Given this list of marker genes ARHGAP27, CDH10, NT5DC1, TEN1, ECRG4, AMD1, PYCARD, NEFH, DNALI1, PIGT, GLI3, TIGD2, MOXD1, SFT2D3, POMT1, KIAA1191, TOP6BL, SMTN, TMEM150C, ME3, SRRD (SRR1 domain containing), PGM5, COL8A2, PARM1, NEXN, ARHGEF10, RAB34, SERPINB5, RAMP2, PAK1, ROBO2, KAT5, FGL2, LINC00339, B3GALNT2, PWWP2B, FOS, RLN1, SORBS1, LSAMP, ISL1, EPHA3, CNOT6L (NCBI Gene Id 91275, CCR4-NOT transcription complex subunit 6 like), DBNDD2, NR2C2AP, SORBS2, FBXO22, ASB2, GABBR1, PDPR (pyruvate dehydrogenase phosphatase regulatory subunit), PPP3CB, CAPS (calcyphosine), BOC, HSPB8, ASAP3, HSD17B14, KLF4, B3GALNT1, PKP1, GTDC1 (NCBI Gene Id 79712), RBM24, KCNN4, SLC15A2, MVK, MVB12B, PSD2, LHPP, MIR100HG (mir-100-let-7a-2-mir-125b-1 cluster host gene), IER2, CACNA2D1, KRT15, RILPL2, PPM1L, VMP1, KLK10, TMSB15A (thymosin beta 15A), EGR2, EGR3, TMEM129, PSPC1, IQGAP2, PPP1R12B, MISP, BBOF1, GLIS2, ERBB2, PAMR1, ROGDI, ATF3, ALDH7A1, MYLK, EPC2, AXIN2, IGFBP2, P2RY1, DUSP1, SCD5, TXNDC11, SOX2, CNTN3, ZFP36, B2M, LRMDA, SWT1, INTS11, ZCCHC3, GSTA4, KLK11, RRAD, DDR2, ARL5A, AZGP1, WFDC1, ACYP2, GPX7, VPS36, PDZRN4, TRMT6, PTGS2, SFRP1, RBFOX3 (RNA binding fox-1 homolog 3), CDNF, UPK3A, KLF3, FBXO2, RPS27L, GHDC, EYA4, FGFR2, THBS4, ALKBH3 (NCBI Gene Id 221120), CUEDC1, BMP4, BMP7, ZMYND11, PCDH7, HPS1, TBC1D9B, OGN, MEGF6, ITIH5, FGF13, DEF6, LIMS2, HEXA, ILDR1, TMEM106B, NFIA, LINC00662, FMOD, RORB, FAM3B, CCN2, ZNF483 (NCBI Gene Id 158399), BMPR1A, EIF3J, SMAGP, BTG2, XAB2, ANTXR2, MXRA5, SMOC2, SPATC1L, GSTO2, ADIRF (adipogenesis regulatory factor), APCDD1, RAB40B, EPHB6, THSD4, KLK3, PODN, STARD13, DNAJC10 (DnaJ heat shock protein family (Hsp40) member C10), EIF3A, ENSG00000293268, MED11, PNRC2, SERTM2, PI15, NSMCE4A, SCN7A, CNST, EVA1C, TNS1, SEMA3C, SLC30A4, CHRM3, RAB27B, PDGFC, MN1, RARRES1, CD38, PTPRN2, TMEM98, CLCN7, PDE4B, RWDD2B, PRICKLE2, EFS, NDFIP2, ARMCX1, ITGB8, SYNGR4, SELENOM, TRIM29, CAB39L, SMIM1, AMDHD2, TWIST2, RNF10, CTSO, C11orf52, MRPL45, FOSB (NCBI Gene Id 2354), ZNF641, SLC20A2, KRT5, CACHD1, FAM135A, ALOX15B, MRGPRF, SMPDL3B, SSPN, TSHZ3, MAN2B2, MX1, MTPAP, ITGA4, EFEMP2, ECHDC1, PRPF40A, TRAPPC1 (NCBI Gene Id 58485), SYTL1, AHNAK2, ANXA11, DPP4, PMEPA1, TMEM199, TNIP1, DYNC1I2, RAB23, FHOD3, CIMAP3, MCC (MCC regulator of WNT signaling pathway), SYS1, SYNPO2, ZNF747, FUCA1, AHI1, ZBTB4, RGCC, DPH3 (NCBI Gene Id 285381), GSTM5, COL13A1, CWH43, NECAB3, TSPAN15, PPP1R14A, MAGED2, RNF150, PCDH18, GSTT2, ANKH, DUSP2, NAGLU, KLF6, RRAS, IDNK, PER3, LFNG, CCN3, PCOLCE2, ANO7, WFDC2, TM9SF1, PTN, NDNF, MCTP2, SLC22A17 (NCBI Gene Id 57100), MAP3K20, RNF180, STAT2, BCAS1, GOLM1, VSIG2 (V-set and immunoglobulin domain containing 2), CRISPLD2, CIRBP, NINJ2, NR4A1, RNF43, FAM107A, PSD3, RASL12, JAM3, MICA, SMAD3, DACT3, MLLT10, CAV2, RAB4A, PRRX1, HECW2-AS1, PDE5A, NBL1, SPOCK3, CFL2, TSPAN2, SLMAP, MYG1, LPAR1, TUBB6, WNT5B, ZNF532, IRAG1, RASSF4, CYBRD1, here is a description of the gene set: species: Homo sapiens Genes down-regulated in metastatic tumors from the whole panel of patients with prostate cancer. BACKGROUND: Prostate cancer is characterized by heterogeneity in the clinical course that often does not correlate with morphologic features of the tumor. Metastasis reflects the most adverse outcome of prostate cancer, and to date there are no reliable morphologic features or serum biomarkers that can reliably predict which patients are at higher risk of developing metastatic disease. Understanding the differences in the biology of metastatic and organ confined primary tumors is essential for developing new prognostic markers and therapeutic targets. METHODS: Using Affymetrix oligonucleotide arrays, we analyzed gene expression profiles of 24 androgen-ablation resistant metastatic samples obtained from 4 patients and a previously published dataset of 64 primary prostate tumor samples. Differential gene expression was analyzed after removing potentially uninformative stromal genes, addressing the differences in cellular content between primary and metastatic tumors. RESULTS: The metastatic samples are highly heterogenous in expression; however, differential expression analysis shows that genes are upregulated and genes are downregulated at least 2 fold in every patient with metastasis. The expression profile of metastatic samples reveals changes in expression of a unique set of genes representing both the androgen ablation related pathways and other metastasis related gene networks such as cell adhesion, bone remodelling and cell cycle. The differentially expressed genes include metabolic enzymes, transcription factors such as Forkhead Box M1 (FoxM1) and cell adhesion molecules such as Osteopontin (SPP1). CONCLUSION: We hypothesize that these genes have a role in the biology of metastatic disease and that they represent potential therapeutic targets for prostate cancer. Human Gene Set: CHANDRAN_METASTASIS_DN from publication Chandran UR, Ma C, Dhir R, Bisceglia M, Lyons-Weiler M, Liang W, Michalopoulos G, Becich M, Monzon FA (PMID 17430594)